Given this list of marker genes KATNAL1, SLK, CLIP4, CEP120, DYNC1H1, CLIP1, KATNBL1, KPNB1, RAB11A, DLG1, CAMSAP2, CENPJ, TPPP, TUBGCP2, KIF19, CHP1, TUBG2, KATNA1, CLIP2, SLAIN2, STMN3, PCM1, SLAIN1, TBCB, PPFIA1, PDE4DIP, HOOK2, CEP126, KATNB1, KIF21A, CRIPT, WDR73, PPFIBP1 (PPFIA binding protein 1), MAP10, EZR, FSD1, TUBGCP3, CCDC88A, IFT172, CCDC13, NUMA1, TUBGCP6, TRDN, TRPV4, PLK3, CIB1 (calcium and integrin binding 1), TUBGCP4, RHOA, HOOK3, LIMK2 (LIM domain kinase 2), CLIP3, MAPT, CCDC88B, CCDC88C, TLN1 (talin 1), KATNAL2, TUBGCP5, DVL1, HOOK1, TUBG1, PAFAH1B1, CLASP1, AXIN1, KANK1, CAV3, here is a description of the gene set: studied in species Homo sapiens A process that is carried out at the cellular level which results in the assembly, arrangement of constituent parts, or disassembly of structures formed of microtubules and associated proteins in the cytoplasm of a cell. Human Gene Set: GOBP_CYTOPLASMIC_MICROTUBULE_ORGANIZATION